The following is a description of a gene set: Mutation-activated KIT to RAS-ERK signaling pathway. Pathway ID: N00003. Pathway type: Variant. Pathway class: nt06275 Acute myeloid leukemia. Human Gene Set: KEGG_MEDICUS_VARIANT_MUTATION_ACTIVATED_KIT_TO_RAS_ERK_SIGNALING_PATHWAY studied in species Homo sapiens Pathway Definition from KEGG: KIT* -> GRB2 -> SOS -> RAS -> RAF -> MEK -> ERK, and this is the list of marker genes: MAPK1 (NCBI Gene Id 5594), MAP2K1, MAPK3, KRAS, KIT, ARAF (A-Raf proto-oncogene, serine/threonine kinase), RAF1, GRB2, SOS2, BRAF, NRAS, MAP2K2, HRAS, SOS1